Given this list of marker genes Lyve1, Cemip, Hmmr (hyaluronan mediated motility receptor (RHAMM)), Abcc5, Cd44, Stab2, Hyal1, Hyal2, Has2, Hyal3, Gusb, Hexb, Hexa, Chp1, Slc9a1, Has3, Has1, here is a description of the gene set: species: Mus musculus Hyaluronan metabolism Mouse Gene Set: REACTOME_HYALURONAN_METABOLISM